Given this list of marker genes CUL3, CPEB4, AMPD1, CSRP3, TANK, SLC1A7, CACNA2D3, ZFHX3, RASGRF1, KLF14, ASAP1, TSC22D1, CMTR2, HDAC9, SNAP25, COX14, PSMA8, SND1-IT1, PTCH1, ELP4, NEUROG1 (NCBI Gene Id 4762), CA4, PCDH18, POC1B, ATF3, NFKBIA, DMD, GNAO1 (G protein subunit alpha o1), SMAD5, PRRX1, HOXC5, PBX2, MYPN, LZTS2, VLDLR, CYTH3, BHLHE22, SMPX (small muscle protein X-linked), ZMIZ1, ATP1A2, MAP2, ZDHHC8, CMTM4, MYOZ3, GNAT2 (G protein subunit alpha transducin 2), DDX17, IMMP1L, NR4A1, ZNF516-DT, REEP3, PRDM1, PIK3R3, TLK2, TSHZ3, AP1S2, BMAL1, HEY1, ITGA10, RBFOX1, FBXO36, ARL4C, GSC, PTPN1, LINC01089, PSMC3IP, SPTSSA, CHD4, SKIDA1, PNOC, RARB, CTNND2, here is a description of the gene set: Human Gene Set: YWATTWNNRGCT_UNKNOWN from publication Xie X, Lu J, Kulbokas EJ, Golub TR, Mootha V, Lindblad-Toh K, Lander ES, Kellis M (PMID 15735639) studied in species Homo sapiens Comprehensive identification of all functional elements encoded in the human genome is a fundamental need in biomedical research. Here, we present a comparative analysis of the human, mouse, rat and dog genomes to create a systematic catalogue of common regulatory motifs in promoters and 3' untranslated regions (3' UTRs). The promoter analysis yields 174 candidate motifs, including most previously known transcription-factor binding sites and 105 new motifs. The 3'-UTR analysis yields 106 motifs likely to be involved in post-transcriptional regulation. Nearly one-half are associated with microRNAs (miRNAs), leading to the discovery of many new miRNA genes and their likely target genes. Our results suggest that previous estimates of the number of human miRNA genes were low, and that miRNAs regulate at least 20% of human genes. The overall results provide a systematic view of gene regulation in the human, which will be refined as additional mammalian genomes become available. Genes having at least one occurrence of the highly conserved motif M173 YWATTWNNRGCT in the regions spanning 4 kb centered on their transcription starting sites. The motif does not match any known transcription factor binding site.